The following is a description of a gene set: Human Gene Set: GOMF_D_GLUCOSE_SODIUM_SYMPORTER_ACTIVITY studied in species Homo sapiens Enables the transfer of a solute or solutes from one side of a membrane to the other according to the reaction: D-glucose(out) + Na+(out) = D-glucose(in) + Na+(in)., and this is the list of marker genes: SLC5A2, SLC5A10, SLC5A3, SLC5A11, SLC5A4 (NCBI Gene Id 6527), SLC5A1, SLC5A9